The following is a description of a gene set: Combining with glutamate and transmitting the signal from one side of the membrane to the other to initiate a change in cell activity. Mouse Gene Set: GOMF_GLUTAMATE_RECEPTOR_ACTIVITY species: Mus musculus, and this is the list of marker genes: Grik2, Grid2, Grm6, Grik5, Grin2d, Grin2b, Grid1, Grin1, Grin3a, Grm2, Grm3, Grm5, Grin2c, Grm7, Grm8, Grm4, Grin3b, Grin2a, Grm1, Gria2, Grik4, Grik3, Gria3, Gria1, Gria4, Grik1